Given this list of marker genes ZNF641, GYPC, CKMT2, STAB1, TMEM50B, ZNF404, CLEC11A, COX7A1, EVA1B, CHPF2, GMFG, MIR29B2, PARP10 (poly(ADP-ribose) polymerase family member 10), PABIR1, NR1H2, NBN, EHD1, MS4A6A, EP400, FRMD4A, TULP4, EPM2A-DT, R3HDM1, PGGHG, BIN1, PTP4A3, KLHL2, AHR, NME3, TTC17, ZBTB17, GATA2, AMY2B, IRF3, TSPAN4, MR1 (NCBI Gene Id 3140), SLC25A37, HEMK1, MKKS, TFDP2, ZSCAN16, SASH3, WASHC3 (WASH complex subunit 3), FAM3A, THEM4, LAMP5, MVP, TOB2, GGTA1, CLU (clusterin), PTPN4, DDX24, SELENOM, DISP1, CCR10, SLC39A3, CNRIP1, TRPV2, INSYN1, AQP1, RASSF7, STRN, NALCN, GALNT6, ACADS, SECISBP2, REX1BD, ISOC2, INO80D, DUOX2, UBN2, CD34, RND1, NAGK, SELPLG, PLEKHA2, KLHL22, SIRPAP1, PPM1M, RGL1, HLA-DRA, PHLDA3, MARCHF2, RIN2, SIRPA, LINC00869, CPPED1, PDK2, ACACB, HP, DOK1, PRAG1, REXO1, RASSF4, ZBTB20, DAB2, SPON2, VWA5A, SLC52A3, NUDT6, TMC5, SIL1, FADS3, F13A1, AKAP13, FAM174C, ATP8B4, PARM1, FBXO32, PIP, C14orf28, TBC1D8B, ARHGAP6, GABARAPL1, NHS, SLC25A20 (solute carrier family 25 member 20), ABHD17A, RAB4B, SLA, CORO1A, BRWD1, C3orf85, PRRX1, PGAP3, SEMA5A, CFLAR (NCBI Gene Id 8837), TAF3, LINC01770, TNFRSF1A, ACTN1 (actinin alpha 1), ANO10, STK11, MAN2B1, BRMS1, PPFIBP1, PWWP3A, STK17B, DTWD1 (NCBI Gene Id 56986), NEIL2, RNASEL (NCBI Gene Id 6041), POU5F1, RNF213, ITGAL, TUT7, APOL6, GTF2F1, CIRBP (NCBI Gene Id 1153), CTBP2, SIDT2, ZNF45, TLR5, PTK2B, LPAR5, ENG, GSDMD, here is a description of the gene set: from publication Bidus MA, Risinger JI, Chandramouli GV, Dainty LA, Litzi TJ, Berchuck A, Barrett JC, Maxwell GL (PMID 16397028) species: Homo sapiens Human Gene Set: BIDUS_METASTASIS_DN Genes down-regulated in endometroid endometrial tumors from patients with lymph node metastases compared to those without the metastases. PURPOSE: To characterize the gene expression profiles of endometrioid endometrial cancers associated with lymph node metastasis in an effort to identify genes associated with metastatic spread. EXPERIMENTAL DESIGN: Tumors from 41 patients with endometrioid endometrial cancer grossly confined to the uterine cavity were evaluated. Positive lymph nodes were noted in 12 of 41 patients. RNA was analyzed for gene expression using the Affymetrix HG133A and HG133B GeneChip set, representing 45,000 array features covering >28,000 UniGene clusters. Data analysis was done using multidimensional scaling, binary comparison, and hierarchical clustering. Gene expression for several differentially expressed genes was examined using quantitative PCR. RESULTS: Gene expression data was obtained from genes that were detected in at least 5% of the cases. Supervised analysis of node-positive versus node-negative cases indicated that genes were significantly differentially expressed between the two classes at P < 0.005, 81 of which were differentially expressed by at least 2-fold at P < 0.005. Overexpressed genes included two cell cycle checkpoint genes, CDC2 and MAD2L1, which have previously been described in association with lymph node metastasis in other cancer types. The ZIC2 zinc finger gene was overexpressed in endometrial cancers with positive nodes versus those with negative nodes. CONCLUSION: Gene expression profiling of the primary tumors in patients with endometrioid endometrial cancers seems promising for identifying genes associated with lymph node metastasis. Future studies should address whether the status of nodal metastasis can be determined from the expression profiles of preoperative tissue specimens.